Given this list of marker genes HNF1B, FGF9, SOX11, ALDH1A2, IHH, SIX2, STRA6, NIPBL (NCBI Gene Id 25836), SALL1, PCSK5, PKDCC, HLX, PDGFRA, TGFB2, SCT, ID2, PITX2, FGFR2, MYB, ADA, FOXF2, CXCL8, TCF21, FOXF1, TNF, FGF10, OVOL2, GLI2, RARB, RARRES2, VPS52, SHH, RBPMS2, GLI3, SHOX2, here is a description of the gene set: species: Homo sapiens Human Gene Set: GOBP_EMBRYONIC_DIGESTIVE_TRACT_DEVELOPMENT The process whose specific outcome is the progression of the gut over time, from its formation to the mature structure during embryonic development. The gut is the region of the digestive tract extending from the beginning of the intestines to the anus.